Given this list of marker genes FYN, JAZF1 (JAZF zinc finger 1), GRAMD1C, PRSS35, ZFHX4, MAP1B, CREB5, TEAD1, ATP5MC2, CLRN1, MRAS, CCSER2, NMU, TBX4, ADCY8, HOXC5, POGZ, NRXN1, PSPN, ZFPM2, ASB4, SRSF6, GFRA3, FN1, ATRX, GOLT1A, BDNF, HOXB5, ANKRD29, DRD5, OTX1, SOX4, RXRG, CTNND1, PAK6, MEF2C, POU3F2, ZNF503, DMD, LINC01164, ESRRG, RAB30, ESR1, SARS1, MIR503HG, NOVA1, PHC2, HIVEP3, CASQ2, CD226, GRIA3, TCF21, MAP2K7, MIR137HG, SEMA3C, CAB39L, GAS2, ASCL3, MSR1, LRRC2, SIX6, SP6, SOX5, TCF12, SH3BP5, CLDN8, AGPAT4, ALKBH3, KPNA3, LIF, MAB21L3, GEMIN4, IGF2BP3, CTNNA2, HOXB6, LAMTOR3, FGF7, CCND1, FRMPD1, SAAL1 (NCBI Gene Id 113174), LSAMP, SRPK2, CRISP1, HOXA6, GABRA1, CCDC80, GREM1, CDH13, SLC25A25, STC1, TMEM117, RNF111, KCNK16, SALL1, C1orf43, DEPTOR, BCORP1, KLF15, PBK, HOXA2, FAM133A, TSHZ2, OR10J1, LHFPL6, PLPP1, CTLA4, PAX2, DGCR8, NECTIN3, HOXA5, CNPPD1, LRP2, OTOP2, VPREB3, CDON, RUNX1T1, HOXC8, TSGA10, GPX1, IL21, CES5A, KRT9, SOHLH2, NAA40, FOXN3, C8orf17, SIX3, GSS, MYOT, GPBP1, IL25, OFCC1, CIBAR1, CRIM1, CDH6, CLMN, SPACA9, SNCA, PCDHGC3, WNT2, PITX2, CHRDL1, ARHGAP36, FLRT1, AGTR2, POU4F2, COLEC12, REN, VPS50, HOXD10, CCNG2, NRXN3, ELAVL4, JMJD1C, HOXD3, ALX3, TGIF1, LCP1, KCNA3, GRB10, FGF14, ZRANB1, ARHGAP4, ITGB8, AGR2, HOXA7, MEIS2, EMILIN2, HIBADH, MAP3K3, CARD11, HOXC4, RANGAP1, ZNF485, VSTM2L, MAPK8, CAVIN2, HS3ST4, IARS1, SNAP25, RASGRF2, MLIP, CDCA7, SIX1, PRKRIP1, LINC00671, STK31, PTEN, HOXB7, SND1, SLC2A12, RALYL, NMNAT3, FOXP2, TSC1, ARPC5L, ZBTB20, AK8, SLC6A5, NIPBL, HBP1, MROH2B, CACNA1E, NR5A1, USP5, HNRNPA0, PCLAF (NCBI Gene Id 9768), SLCO2A1, ITSN1, GDNF, RP1L1, CRYZL1, ACTL6A, C12orf42, GPR17, CDX2, TLK1, PPARGC1A, USH1G, ROBO3, CALN1, FGF20, IP6K2, NRP2, HOXA9, NMNAT2, RIMS2, DMBT1, NIPAL3, ANXA2, ZNF521, JOSD1, EBF1, MYBPC1, VWA3B, MID1, LRMDA, FAM110D, CLSTN2, CASKIN1, C3orf36, TRERF1, HOXB8, HOXD11, GPX2, CHN1 (chimerin 1), POU2F1, HOXA3, GOLGA1, PPP2R2A, ZHX2, DSC1, JPH4, VAV3, CCDC186, G6PC1, NPPB, WDPCP, GPR18, GALNT7, NAP1L3, DTNA, KLHL1, CD36, WASL, CADM2, GPM6A, GNB3, CDK14, ARFGEF1, ALDH1A2, HOXB9 (NCBI Gene Id 3219), CPO, HERC1, LDB2, SP8, ARL4C, HOXD9, ZIC1, CRB1, XPR1, ALPK2, BRINP3, FBXO32, SRC, CNKSR1, ZIC4, TMEM178A, JAK1, C1QTNF7, VCPKMT (valosin containing protein lysine methyltransferase), RELCH, MAPK10, UPK1A, FGFR4, GUCA1C, here is a description of the gene set: Genes having at least one occurrence of the highly conserved motif M94 TGATTTRY in the regions spanning 4 kb centered on their transcription starting sites. This matches the GFI1 transcription factor binding site V$GFI1_01 (v7.4 TRANSFAC). Comprehensive identification of all functional elements encoded in the human genome is a fundamental need in biomedical research. Here, we present a comparative analysis of the human, mouse, rat and dog genomes to create a systematic catalogue of common regulatory motifs in promoters and 3' untranslated regions (3' UTRs). The promoter analysis yields 174 candidate motifs, including most previously known transcription-factor binding sites and 105 new motifs. The 3'-UTR analysis yields 106 motifs likely to be involved in post-transcriptional regulation. Nearly one-half are associated with microRNAs (miRNAs), leading to the discovery of many new miRNA genes and their likely target genes. Our results suggest that previous estimates of the number of human miRNA genes were low, and that miRNAs regulate at least 20% of human genes. The overall results provide a systematic view of gene regulation in the human, which will be refined as additional mammalian genomes become available. species: Homo sapiens Human Gene Set: TGATTTRY_GFI1_01 from publication Xie X, Lu J, Kulbokas EJ, Golub TR, Mootha V, Lindblad-Toh K, Lander ES, Kellis M (PMID 15735639)